The following is a description of a gene set: Human Gene Set: MIR513C_5P from publication Chen Y, Wang X (PMID 31504780) studied in species Homo sapiens Genes predicted to be targets of miRBase v22 microRNA hsa-miR-513c-5p in miRDB v6.0 with MirTarget v4 prediction scores > 80 (high confidence targets)., and this is the list of marker genes: SHROOM3, GABRB3, TRMT6, BTG3 (BTG anti-proliferation factor 3), ABLIM1, SRR, MPZL1, UBR4, THPO, PPP1R9A, GASK1B, RBM39, CKAP2, KATNBL1, SMAD4, INTS5, BRI3, TIPRL, MARCHF3, SLC36A4, YTHDC2, KLHL11, DNAJC15, PPP4R3A, ZNF264, ZNF90, IRF2BP1, AGXT2, ZNF711, UACA, PRDM16, MINDY2, FBXO45, ZFP69, PTGES3, GPATCH2, IBTK, MET, ATP11B, ZNF283, SYN1, NIPAL4, KCNQ3, ALG13, SEZ6L, NCK2, ABL2, SIPA1L3, TMEM123, ADAM9, RCN1, SLC30A8, SLC26A9, ANKS1B, CCSER2, LSM2, MRPL44, RABGAP1L (RAB GTPase activating protein 1 like), ZNHIT6, SRGAP2, UBE3A, TMEM64 (NCBI Gene Id 169200), BCKDHB, VAMP1, TIFA, AP1AR, DVL3, PLXDC2, NDUFA4, COMMD4, NFIA, RUNDC3B, ARPC5L, BCLAF1, ZNF100, STAMBP, LTBP1, GNG2, SYTL2, ARMC8, SBSPON, ZNF273, PHTF2, RREB1, NUFIP2, GXYLT1, FGF21, GPR137B, LMAN1, GPM6B, VCPIP1, PI4K2B, TOB1, BRWD1, PDE3B, ZKSCAN2 (zinc finger with KRAB and SCAN domains 2), RNMT, AGO1, ZNF730, KCTD12, NAA50, GMFB, CLIC4, ZBTB20, HMBOX1, TADA2B, BRCA2, HNRNPR, ANGPT2, GON7 (NCBI Gene Id 84520), RAI14, UBE2K, RFX3, EIF2AK1 (NCBI Gene Id 27102), TM6SF1, RNFT2, CCDC47, PPTC7, NFYB, CNTNAP2, ZNF680, VGLL3, NECAB1, KCNAB1, IGF2BP1, TRAM1, SLTM, ITPR2, MAP3K2, SIKE1, MCTP2, GPR158, GPRIN3, ATP6V0A2, LRBA, KRTAP2-3, RASGEF1A, PTGR2, CLDN22, COMMD2, FOLR1, DLX1, DAPP1, DBP, PRKAA2, SIRPB1, FCF1, KSR2, MAT2B, PTPN4, CBR4, SKIL, PEX12, NCOA3, NBEA, IPCEF1, LRATD2, TMEM33, SEPSECS, MTMR4, POGLUT1, UPF2, SAMD8, KLHL20 (NCBI Gene Id 27252), RC3H1, TRIM37, PLEKHA3, CLEC1A, HYLS1, ZYG11B, PLEKHH2, ZNF318, PTRH2, PTER